The following is a description of a gene set: Shivering Involuntary contraction or twitching of the muscles. species: Homo sapiens Human Gene Set: HP_SHIVERING, and this is the list of marker genes: CD28, TNFRSF1B, CTLA4, CHRNA2, HADHA, HADHB